The following is a description of a gene set: Binding to an odorant, any substance capable of stimulating the sense of smell. studied in species Homo sapiens Human Gene Set: GOMF_ODORANT_BINDING, and this is the list of marker genes: OR5B2, OR10Q1, OR5C1, OR14I1, OR5AC2, OR8H1, OR13G1, OR10J4, OR6N2, OR5J2, OR9G4, OR5M9, OR5M3, OR12D2, OR14K1, OR5AN1, OR10K2, OR5D13, OR8I2, OR8H3 (NCBI Gene Id 81171), GPR148, OR10J3, OR10V1, OR5K4, OR5T3, OR5D18, OR9I1, OR5M8, OR2A7, OR5AP2, OR14C36, OR5D14, OR5K3, OR9Q1, OR5H14, OR10J1, OR5M1, OR8B12, OR9Q2, OR5W2, OR2A4, OR6K3, OR6B2, OR14L1, OR10R2, OR5L2, OR5G3, OR5P2, OR10T2, OR5T1, OR5H8, OR5B12, OR5H15, OR8G5, OR8G2P, OR5AU1, OR5P3, OR5K1, OR5L1, OR14A2, OR6K6, OR5AK3P, OBP2A, OR10Z1, OR8D4, OR10W1, OR8B8, OR8H2, OR5H1, OR2C1, OR13A1, OR8G3P, OR8A1, OR8B2 (olfactory receptor family 8 subfamily B member 2), OR14A16, OR10K1, OR5B3, OR4E2, OR6B3, OR12D1, OR5F1, OR5H2, OR4E1, OR9K2, OR5M10, OR5K2, OR8B4, OR5A2, OR5AR1, OR8B3 (olfactory receptor family 8 subfamily B member 3), OR5A1, OR5B17, OR5H6, OR5AC1, OR1K1, OR5I1, OR5D16, OBP2B, OR11L1, OR14J1, OR5AS1, OR5AK2, OR5BS1P, OR12D3, OR6K2, OR5T2, OR5B21, OR2A25, OR8D2, OR8D1, OR8G1